The following is a description of a gene set: Human Gene Set: HP_ABNORMAL_CELL_MORPHOLOGY Any anomaly of cell structure. studied in species Homo sapiens Abnormal cell morphology, and this is the list of marker genes: RYR1, TNNT2, PANX1, LIG3, ZP2, ACTN2, ZFTA, DOLK, TP53, DNAJC21, GYG1, VCL, ACTC1, RTEL1, PNPLA2, PARN, PEX6, TYMP, RPL3L, ALPK3, PATL2, ZCCHC8 (NCBI Gene Id 55596), TUBB8, POLG, TERT, MDM4, ATXN2, WEE2, ACD, CACNA1S, DSP, POT1, LMOD2, TINF2, COA5, ZP1, TYMS, RPA1, WRAP53, KLHL24, NOP10, RRM2B, TNNI3